Given this list of marker genes FGF21, RPS6KB2, FGF23, MTOR, AKT3, FGF22, FGF6, FGF7 (fibroblast growth factor 7), AKT1, FGF5, FGF2, FGF18, FGFR2, FGF9, FGF1, FGF3, FGFR3, RPS6KB1, FGF19, FGF16, FGF10, FGF20, FGF17, AKT2, FGF8, FGFR4, FGF4, PIK3CD, PIK3CA, PIK3CB, FGFR1, here is a description of the gene set: species: Homo sapiens FGF-FGFR-PI3K signaling pathway. Pathway ID: N00037. Pathway type: Reference. Pathway class: nt06261 Gastric cancer. Pathway Definition from KEGG: FGF -> FGFR -> PI3K -> PIP3 -> AKT -> MTOR -> S6K Human Gene Set: KEGG_MEDICUS_REFERENCE_FGF_FGFR_PI3K_SIGNALING_PATHWAY